The following is a description of a gene set: studied in species Mus musculus from publication Chen Y, Wang X (PMID 31504780) Mouse Gene Set: MIR_3618_5P Genes predicted to be targets of miRBase v22 microRNA mmu_miR_3618_5p in miRDB v6.0 with MirTarget v4 prediction scores > 80 (high confidence targets)., and this is the list of marker genes: Snx18, Pabir2, Prokr2, Pdlim5, Slc1a2, Osbpl3, Plcb1, Rcor3, Aldh3a2, Prl8a6, Jazf1, Add3, Cyld, Ets1, Asxl2, Wif1, Pam, Zfp275, Nhlrc2, Slain2, Cdc40, Kctd8, Ap1s2, Enpp2, Pdyn, Lipm (lipase, family member M), Zfp292, Nid1, Mindy3, Nipbl (NCBI Gene Id 97967), Map2k3, Strip2, Peg3, G6pc1, Phf6, Dnaja4, Rpe, Dhx40, Unc5c, Mgat2, Cntn4, Col11a1, Maff, Vcan (NCBI Gene Id 71433), Fgf7, Zfp677, Slc4a10, Dnm1l, Slfn8, Eif4g3, Bicdl2, Eif4e, Donson (NCBI Gene Id 68649), Arhgap6, Usp42, Slco1a1, Fhl4, Ctbp2, Chodl, Znrf3, Mtmr12, Serpina12, Clec14a, Asz1, Hoxd13, Ubxn10, Macf1, Nr3c2, Ctps2, Nudt17, Cnksr2, Rlim, Mfap5, Mep1a, Lrrtm2, Trp73, Fam117b, Kansl1l, Pros1, Nbeal1, Klf11, Prlr, Pcbp1, Arfip1, Glis3, Agk, Calcr, Tox3, Hspd1, Itga4, Tpp2, Xiap, Kctd1, Pogz, Trip4, Lrch2, Usp10, Golim4, Ccdc71l, Gramd2b, Tmpo (thymopoietin), Rbfox3, Selenoi, Ahr, Pag1, Dpys, Gigyf2, Neurod1, Dclk1, Ppm1d, Foxa1 (forkhead box A1), Arhgap42, Slc12a1, Slc39a6, Ank3, Rex2, Prdm15, Oas1f, Ankfn1, Id2, Zfp980, Cert1, Nhsl2, Fam107b, Calcoco1, Cntrl, Pkib, Sis, Phb1, Sfrp1, Alox5ap, Mob1a, Csad (cysteine sulfinic acid decarboxylase), Ogfrl1 (opioid growth factor receptor-like 1), Chm, Alg5, A1cf, Ppp1r3b, Gpr161, Cyp4a14, Arpp21, Scn7a, Dab1, Srpx, Cpne3, Myoc, Hivep3, Atp5f1a, Gpc6, Ube2e2, Spred1, Atl2, Fermt1, Apool, Zfp53, Spry1, Ikzf2, Zfp600, Pex1, Epn3, Rnft1, Acad8, Srrm4, Dcp1b, AI593442, Pxdn, Dpyd, Hecw2